Given this list of marker genes NHP2, CCT6A, PARN (NCBI Gene Id 5073), NAF1, CCT7 (NCBI Gene Id 10574), SHQ1, CCT4, WRAP53, RUVBL2, DKC1, DCP2, CCT3, EXOSC10, CCT5, NOP10, CCT8, CCT2, TCP1, RUVBL1, here is a description of the gene set: studied in species Homo sapiens Any process in which telomerase RNA is transported to, or maintained in, a specific location. Human Gene Set: GOBP_TELOMERASE_RNA_LOCALIZATION